The following is a description of a gene set: Any process that results in a change in state or activity of a cell or an organism (in terms of movement, secretion, enzyme production, gene expression, etc.) as a result of a cold stimulus, a temperature stimulus below the optimal temperature for that organism. Mouse Gene Set: GOBP_RESPONSE_TO_COLD studied in species Mus musculus, and this is the list of marker genes: Chrna7, Scn11a, Rbm3, Plin1, Agt, Hspd1, Hspa2, Appl2, Ucp2, Bltp1, Tmem135, Ces1d, Trpa1, Adrb2, Trpm8, Rnf34, Zfp516, Lipe, Pparg (NCBI Gene Id 19016), Ucp3, Ucp1, Cidea, Lipa, Thra, Cirbp, Adrb1, Plac8, Eif2ak3, Cdh8, Metrnl, Acadm, Acadl, Acadvl, P2rx3, Mcrip2, Nfe2l1, Slc9a1, Hsp90aa1, Acot11, Lncbate10, Pcsk1n, Slc25a27, Adrb3, Dnajc3, Fcor, Slc27a1, Lrp11, Eif2ak4, Saxo1, Prkaa1, Vgf, Prkaca, Abraxas2